The following is a description of a gene set: Dendritic cells (DCs) are the sentinels of the mammalian immune system and they undergo a complex maturation process mediated by activation upon pathogen detection. Recent studies described the analysis of activated DCs by transcriptional profiling, but translation regulation was never taken in account. Therefore, the nature of the mRNAs being translated at various stages of DC activation was determined with the help of translational profiling, which is the sucrose gradient fractionation of polysomal-bound mRNAs combined to microarrays analysis. Total and polysomal-bound mRNA populations were compared in immature (0h) and LPS-stimulated (4h and 16h) human monocyte-derived DCs with the help of Affymetrix microarrays. Biostatistical analysis indicated that 296 mRNA molecules are translationally regulated during DC-activation. The most abundant biological process among the regulated mRNAs was protein biosynthesis, indicating the existence of a negative feedback loop regulating translation. Interestingly, a cluster of 17 ribosomal proteins were part of the regulated mRNAs, indicating that translation may be fine-tuned by particular components of the translational machinery. Our observations highlight the importance of translation regulation during the immune response, and may favour the identification of novel gene clusters or protein networks relevant for immunity. Our study also provides information on the possible absence of correlation between gene expression and real protein production in DCs. from publication Ceppi M, Clavarino G, Gatti E, Schmidt EK, de Gassart A, Blankenship D, Ogola G, Banchereau J, Chaussabel D, Pierre P (PMID 19943945) Human Gene Set: GSE14000_UNSTIM_VS_16H_LPS_DC_TRANSLATED_RNA_DN Genes down-regulated in comparison of polysome bound (translated) mRNA before and 16 h after LPS (TLR4 agonist) stimulation. studied in species Homo sapiens, and this is the list of marker genes: STAT2, CYP27B1, RAB30, TNFAIP1, CNTLN, ADAM19 (ADAM metallopeptidase domain 19), CFLAR, NBN (nibrin), MICB, WARS1, USP18, FSD1L, MYH11, HILPDA, TMEM268, HERC5, INSL4 (NCBI Gene Id 3641), STARD4, SP100, PNRC1, PI4K2B, NAA25, BCL2A1, DNAI3, BRPF3, CYRIA, ZNF32-AS3, APOBEC3G, IL15, C3orf52, GBP1, C4orf46, SGPP2, TNFSF10, BRIP1, IFIT5, APOBEC3A, C19orf12 (chromosome 19 open reading frame 12), MIA, RAB9A, HMGXB3, DRAM1, NFKBIZ, B4GALT5, H2BC21, RUNX3, YPEL5, TNFAIP2, NUB1, PLA1A, GCSAM, KIR2DS2, SAMD9L, USP25, VAV2, FOXP1, BCL2L14, GRB10, MARCKSL1, IFIT3 (NCBI Gene Id 8376), APOL6, ATF3, IFIT2, TWIST1, CMPK2, WHAMM (NCBI Gene Id 123720), TTYH2, MTMR4, MX1, MIR155HG, IL2RA, GMPR, GMDS, CRLF2, HMGCS1, SHFL, AKT3, UBE2Z, CTC1, PMAIP1, ZNF22, RSAD2, PHF11, TMCC3, CNP, CCL5, ADTRP, RABGAP1L, DNAJC6, DEPP1, TNFRSF9, ZNF442, GPR157, GRSF1, SIMC1, UEVLD, ENTPD7, PLAT, SUCO, CKAP4, KIF2A, MASTL, EBI3, GUCY1B1, RAB29, SLCO5A1 (NCBI Gene Id 81796), NT5C3A, LILRA3, CLEC2D, HESX1, TBC1D13, SNX11, CCL20, BIRC3, PARP12, NSD3, GABPB1, GGH, DYNLT1, NEXN, TNFAIP6, CERS6, IDO1, EIF2AK2, NR4A3, CD38, NADK, MX2, IFIT1, GCH1, CPEB2, IFIH1, OAS2, CYB5A, IFITM1, TUBB2A, TMEM41A, PRRG4, FERMT2, EPDR1, DNAAF1, CYTIP, TRIM56, TSPAN13, MAPK8, TOR1B, EAF2, MELK, ARAP2 (ArfGAP with RhoGAP domain, ankyrin repeat and PH domain 2), SFT2D2, INPP5E, NLRC5, ETV1, DNAH3, NOC3L, TRIM69, TNIP2, GTPBP1, IRAK2, FAM222B, OR52K3P, ABTB2, IRF7, TGM1, AIM2, TRANK1, MACIR, HERC6, RAB23, CNOT4 (CCR4-NOT transcription complex subunit 4), FUT4, CR1L, GP1BA, SLAMF7, C1QTNF1, NEURL3, CCL8 (NCBI Gene Id 96488), EEF1AKMT3, SUPT3H, PDGFRL, PDE4B, C1orf21, RALGAPA2, C5orf15, SLC9B2, CXorf58, IFI44L, CCL4, CD274, EHHADH, OAS3, ITGB8, AGFG2 (ArfGAP with FG repeats 2), TXNL4B, SOD2, N4BP2L1, SLC31A2